Given this list of marker genes OFD1, TMEM231, INTU, KIAA0753, TCTN3, KIF7, FAM149B1, PDE6D, CPLANE1, TMEM216 (NCBI Gene Id 51259), TOPORS, here is a description of the gene set: Human Gene Set: HP_CENTRAL_Y_SHAPED_METACARPAL Central Y-shaped metacarpal A central Y-shaped metacarpal is the result of a partial fusion of two central metacarpals (i.e., metacarpals 2-4) of the hand, with the two arms of the Y pointing in the distal direction. Central Y-shaped metacarpals may be seen as a result of a central polydactyly with partial fusion of the duplicated metacarpal. species: Homo sapiens